The following is a description of a gene set: species: Homo sapiens Human Gene Set: GSE30962_ACUTE_VS_CHRONIC_LCMV_SECONDARY_INF_CD8_TCELL_UP Genes up-regulated in comparison of splenic secondary CD8 effector T cells at day 8 post-acute infection versus splenic secondary CD8 effector T cells at day 8 post-chronic infection. from publication West EE, Youngblood B, Tan WG, Jin HT, Araki K, Alexe G, Konieczny BT, Calpe S, Freeman GJ, Terhorst C, Haining WN, Ahmed R (PMID 21856186) Understanding the response of memory CD8 T cells to persistent antigen re-stimulation and the role of CD4 T cell help is critical to the design of successful vaccines for chronic diseases. However, studies comparing the protective abilities and qualities of memory and naïve cells have been mostly performed in acute infections, and little is known about their roles during chronic infections. Herein, we show that memory cells dominate over naïve cells and are protective when present in large enough numbers to quickly reduce infection. In contrast, when infection is not rapidly reduced, memory cells are quickly lost, unlike naïve cells. This loss of memory cells is due to (i) an early block in cell proliferation, (ii) selective regulation by the inhibitory receptor 2B4, and (iii) increased reliance on CD4 T cell help. These findings have important implications towards the design of T cell vaccines against chronic infections and tumors., and this is the list of marker genes: CYTIP, DEDD, CRAMP1, TP53BP2, STK38, SLC25A45, HLA-A, KRTCAP2, CD96, PKD2L2, NRP2, MTO1, PACS1, HECA, CHD3, CD1D, TANC1, EHD3, RPL37A, MTFR1, GSK3B, RNF181, TNFRSF25, MEIS3, VSIR, IQGAP2, MFAP1, INTS6L, MAP2K6, SULF2, DNAJA4, CYP17A1, GMFG, NCALD, NHSL2, RPS27, TPRG1L, PHF21A, SLC4A7, IL7R, ACSS1, GPRIN3, CDC14B, CREBRF (NCBI Gene Id 153222), GABBR1, PARP8, ESM1 (endothelial cell specific molecule 1), CAMSAP2, ACYP1, SBK1, FAM241A, PAPOLB, TKTL1, WFIKKN2, RAB33B, SPICE1, BORCS7, AKT3, MANSC1, CDC20B, GRAMD2B, PGM2L1, MXRA7, NR1D2, ZNF652, TCF7, ST8SIA4, SELENOP, IER3, INSL6, CPNE3, GPX8, TMEM131L, UBE2D1, SARAF, STAP2, YES1, DNAJC15, NCLN, PEX26, GABARAPL2, BRD3, TTC39C, ZEB2, NMU, ICE1, SYCE1L, FNBP1, TSPAN5, CSPP1, MYLIP (myosin regulatory light chain interacting protein), ABTB3, SYN3, LDLRAD4, PLCG1, HSD17B11, ANTXR2, MYOM2, ZNRF3 (zinc and ring finger 3), DTX1, S1PR5, SSH2, CAMKK1, B4GALT1, TCEANC2, AS3MT, CDADC1, ZNF839, CX3CR1, SERINC4, ANKRD17, NT5E, FCGRT, TBX21, RSU1, DPY19L3, SLC20A1, RPL17, TPST2, PITPNC1, PHF13, TTLL4, PRKAB2, TESC, PACC1, TNRC6C, TNFAIP8L2, FRAT2, CIMIP7, PRDM14, RARA, RRAD, IP6K1, RXRA, MFSD14B, SLCO3A1, MBTD1, CBR1, ELOA, UBXN2B, SCML4, BTG2, KLK8, DOCK5, USP3, LRRC8A, FRY, RFX1, KLRD1, PEAK1, CDKN1B, ENSG00000286190, SASH3, ATG16L2, CMA1, LEF1, SGK1, SORBS1, ACSS2, LAIR1, PIK3CD, GALNT10, SH3BP5L, PRR13, ARL4C, SLC49A4 (solute carrier family 49 member 4), FHIP1B, STX1A, ARMC3, C16orf54, AMZ2, RORA, SIPA1L3, RASGRP1, NOTCH2, HID1, GOLM1, CTXN2, ARHGEF2, SERTAD3, C1orf21, ACADM, TP53INP1, RAP2A, GPBP1L1, KCNJ8, RERE, GZMM, NCK2, STAT6, ADAMTS9, DBNDD2, GIMAP1, JAK1, MAML2, GOLIM4, PRUNE1, NOD1, MRPL24, AQP9